Given this list of marker genes GNAQ, HTR1A, HTR1D, HTR7, GNAI1, HTR1F, DRD4, HTR6, HTR2B, PLCB3, HTR1B, GNAO1, GNAZ, HTR2C, ADCY6, HTR5A (NCBI Gene Id 3361), HTR4, HTR2A, HTR1E (NCBI Gene Id 3354), here is a description of the gene set: species: Homo sapiens The series of molecular signals generated as a consequence of a G protein-coupled serotonin receptor binding to one of its physiological ligands. Human Gene Set: GOBP_G_PROTEIN_COUPLED_SEROTONIN_RECEPTOR_SIGNALING_PATHWAY